The following is a description of a gene set: Mouse Gene Set: GOBP_REGULATION_OF_SARCOMERE_ORGANIZATION studied in species Mus musculus Any process that modulates the rate, frequency or extent of myofibril assembly by organization of muscle actomyosin into sarcomeres. The sarcomere is the repeating unit of a myofibril in a muscle cell, composed of an array of overlapping thick and thin filaments between two adjacent Z discs., and this is the list of marker genes: Prox1, Ankrd23, Bmp10, Mylk3 (NCBI Gene Id 676159), Hdac2 (histone deacetylase 2), Akap13, Edn1, Prkd1, Cav3, Mfn2, Mef2c, Ep300